Given this list of marker genes GCM1, BNIP1, L1CAM, ERCC4, BCAT2, SLC14A2, TAF11, ADORA2A, COL14A1, NEFL, TBXA2R, ASMT, PMS2P11, SCAF11, LYST, CENPI, SLC2A4, COX10, TFE3, IDUA, TMEM106A, PDE6G, TAF1, ZNF8, ZNF76, TCF20, AANAT, RING1, MVK, KRT35, TH, ZNF132, GRM4, PTPN5 (NCBI Gene Id 84867), ZNF134, CLCN1, CSN3, WAS, SLC16A1, CLCN7, CD8B, MICB, GJA5 (gap junction protein alpha 5), DPF2, EBI3, TRIP13, CCR9, PRKAG1, MYBPC2, AVPR1B, TTF1, GPR3, PRKCG (protein kinase C gamma), CSPG4, SMARCD1, SLC30A3, ERV3-1, PLK1, AAMP, TIMM17A, GPR31, KRT32, GH2, SLC18A1, MPP2, VAV1, GPER1, CHIC1, SUPT4H1, RABGGTA, RENBP, PDE6B, HTR1E, SCNN1G, HMGA2, ADCYAP1, VPS72, FUT5, DRG2, CYP2F1 (cytochrome P450 family 2 subfamily F member 1), SLC17A2, FUT2, HNRNPL, DGCR6, GSTZ1, PSG7, FCGR2A, MADD, SMARCD2, NDUFA1, SIRPB1, PEX5, FEV, TMEM94, ABCC1, PTPRU, PNMT, IFNA21, TRIM15, FANCC, ODF1, DRD1, AGER, APOC3, EFNA3, here is a description of the gene set: Human Gene Set: GCM_SMARCD1 Neighborhood of SMARCD1 SWI/SNF related, matrix associated, actin dependent regulator of chromatin, subfamily d, member 1 in the GCM expression compendium Neighborhood of SMARCD1 studied in species Homo sapiens